The following is a description of a gene set: species: Homo sapiens Extrinsic Pathway of Fibrin Clot Formation Human Gene Set: REACTOME_EXTRINSIC_PATHWAY_OF_FIBRIN_CLOT_FORMATION, and this is the list of marker genes: F9, F3, TFPI, F10, F7